The following is a description of a gene set: T cell receptor and co-stimulatory signaling Human Gene Set: WP_T_CELL_RECEPTOR_AND_COSTIMULATORY_SIGNALING studied in species Homo sapiens, and this is the list of marker genes: RASGRP1, PDK1 (NCBI Gene Id 5163), PRKCA, CD28, CD8B, ZAP70, DYRK2, PTPN6, RASA1, PDCD1, NFKB1, LCK, CTLA4, GSK3B, ITK, NFATC2, DYRK1A, AKT1, PLCG1, CD8A, CALM1, GSK3A, IL2, NFKBIA, PTEN, CSNK1A1, FYN, PPP3CA